The following is a description of a gene set: Human Gene Set: GOBP_CHOLINE_TRANSPORT The directed movement of choline into, out of or within a cell, or between cells, by means of some agent such as a transporter or pore. Choline (2-hydroxyethyltrimethylammonium) is an amino alcohol that occurs widely in living organisms as a constituent of certain types of phospholipids and in the neurotransmitter acetylcholine. species: Homo sapiens, and this is the list of marker genes: SLC44A3, SLC44A2 (NCBI Gene Id 57368), PSEN1, SLC44A4, SEC14L1, FLVCR2, FLVCR1, SLC44A1, SLC44A5, SLC22A2, SLC5A7